The following is a description of a gene set: RAC3 GTPase cycle Human Gene Set: REACTOME_RAC3_GTPASE_CYCLE studied in species Homo sapiens, and this is the list of marker genes: JAG1, MPP7, EPHA2, ABI1, BCR, CAV1, ARHGAP6, CDC42EP1, PIK3R1, SRGAP2, ARHGAP17, ITGB1, ABI2, NCKAP1 (NCBI Gene Id 9864), CYFIP1, ESYT1, ARHGAP21, DEPDC1B, EMD, NCF2, TFRC, ARHGAP39, FERMT2 (NCBI Gene Id 10979), ARHGAP1, WASF2, BRK1, ARHGAP32, NOX1, WASF1, YKT6, RAC3 (Rac family small GTPase 3), ARHGAP15, NHS, AMIGO2, NCF4, RACGAP1, TMPO (NCBI Gene Id 7112), TAOK3, SYDE1, ARHGAP42, VAV2, ARHGDIB, PGRMC2, SWAP70, ARHGAP26, GIT2, TRIO, SLC1A5, CDC42, MCAM, ARHGAP35, SLITRK3, SNAP23, VANGL1, NOXA1, RAB7A, BAIAP2L1, PREX1, OCRL, PAK2, PAK4, DIAPH3, NOXO1, CYBA (cytochrome b-245 alpha chain), NOX3, ARHGAP5, DOCK10, LMAN1, OPHN1, GARRE1, RAPGEF1, NCKAP1L, LBR, SLITRK5 (NCBI Gene Id 26050), ERBIN, ARAP2, LAMTOR1, LEMD3, VAMP3, CYBB, ARAP3 (NCBI Gene Id 64411), MCF2, IL32, GIT1, DSG2 (desmoglein 2), PAK1, TIAM1, NCF1, STBD1, ABL2, PIK3R2, VRK2 (NCBI Gene Id 7444), BAIAP2, ABR